The following is a description of a gene set: species: Mus musculus from publication Servitja JM, Pignatelli M, Maestro MA, Cardalda C, Boj SF, Lozano J, Blanco E, Lafuente A, McCarthy MI, Sumoy L, Guigó R, Ferrer J (PMID 19289501) Heterozygous HNF1A mutations cause pancreatic-islet beta-cell dysfunction and monogenic diabetes (MODY3). Hnf1alpha is known to regulate numerous hepatic genes, yet knowledge of its function in pancreatic islets is more limited. We now show that Hnf1a deficiency in mice leads to highly tissue-specific changes in the expression of genes involved in key functions of both islets and liver. To gain insights into the mechanisms of tissue-specific Hnf1alpha regulation, we integrated expression studies of Hnf1a-deficient mice with identification of direct Hnf1alpha targets. We demonstrate that Hnf1alpha can bind in a tissue-selective manner to genes that are expressed only in liver or islets. We also show that Hnf1alpha is essential only for the transcription of a minor fraction of its direct-target genes. Even among genes that were expressed in both liver and islets, the subset of targets showing functional dependence on Hnf1alpha was highly tissue specific. This was partly explained by the compensatory occupancy by the paralog Hnf1beta at selected genes in Hnf1a-deficient liver. In keeping with these findings, the biological consequences of Hnf1a deficiency were markedly different in islets and liver. Notably, Hnf1a deficiency led to impaired large-T-antigen-induced growth and oncogenesis in beta cells yet enhanced proliferation in hepatocytes. Collectively, these findings show that Hnf1alpha governs broad, highly tissue-specific genetic programs in pancreatic islets and liver and reveal key consequences of Hnf1a deficiency relevant to the pathophysiology of monogenic diabetes. Mouse Gene Set: SERVITJA_LIVER_HNF1A_TARGETS_DN Genes down-regulated in liver tissue upon knockout of HNF1A., and this is the list of marker genes: Loxl4, Hes6, Ugt3a1, Slc3a1, Elovl3, Lifr, Ang, Slc22a30, Scly, Hopx, Sox6, Fgfr4, Slc30a10, Syt1, Serpina1a, Ccnf, Ifi47, Il1rap, Ugt2b5, Hao1, Slc23a1, Cabyr, Akr1c13, Rtp3, Mcm10, Slc16a10, Ly6e, Akr1c20, Aldh1l1, Mycn, Akr1c6, Arhgap26, Hsd17b2, Slco1b2, Slc25a45, P2ry13, Habp2, Hrg, Cela1, E2f8, Irgm1, Mup5, Adh4, Pigr (polymeric immunoglobulin receptor), Pla2g4a, Kyat1, Slc41a2, Nox4, Ero1b, Fgf1, Cyp2c38, Egfr, Ugt2b1, Cxcl13, Cyp2c29, Dock8, Prkd3, Fmo5, F13b (coagulation factor XIII, beta subunit), Slc37a4, Alas2, Pnpla3, Ctsc, Onecut1, Gbp2b, Ces3b, Dach2, C8a, F11, Lin7a, Cdh1, Pah, C1ra, Cldn14, Serpina9, H2-M10.1, Ugt3a2, Saa1, Adra1b, Bco1, Cyp4v3, Tff3, Camk1d, Cadps2, Ftcd, Polr3k (polymerase (RNA) III (DNA directed) polypeptide K), Lcp1, Akr1c12, Adgrf1, Apcs, Cmah, Cyp26a1, Zkscan1, Sigirr, Acp3, Igfbp4, Serping1, Aass, Fpr-rs4, Prodh2, Scara5, Ugt2a3, Afm, Chrna4, Rdh16f2, Cyp4a12a, C8b, Ppard, Pkhd1, Pdgfc, Bmal1, Cpb2, Mbl1, Sntg2, Ubtf, Hsd3b5, C9, Ppp1r3c, Il13ra1, Cyp2j5, Slc17a3, Fras1, Ugt2b36, Cfhr4, Nrbp2, Eif2s3y, Pla1a, Igf1, Ugt2b38, Nit2, Hsd3b3, Clec2h (C-type lectin domain family 2, member h), Egr1, Fpgs, Bdh2, Cldn2, Mad1l1, Crp, Serpina12, Capn10, Cfi, Rassf5, Cyp2j9, Slco1a1, Fabp1, Saa4, Iigp1, Mmd2, Dct, Cyp4f14, Il1r1, Eef1a2, Igfals, Hc, Cxcl9, Sult5a1, Ptgds, Nr0b2, Cyp7b1, Pip4k2b, Apom, Ugt2b37, C6, Ddc, Nr1h4, Cyp2d9, Slc22a7, Hsd11b1, Itih1, Plg, Celsr1, Esr1, Lect2, Frk, Car5a, Spsb4, Chka, Hsd3b2, Slco2a1, Ror1, Dpp4, Ugt2b35, Tram1, Mup1